Given this list of marker genes Grid2, Epha3, Kirrel1, Tbx18, Serpinb8, Il1rn, Nectin1, Cd40lg, Boc, Blm, Lypd11, Rap2b, Itga5 (NCBI Gene Id 16402), Sftpd, Cldn1, Erf, Pawr, Tjp3, Nckap1l, Cdh3, Adipoq, Itgb8, Celsr2, Ctnnd1, Alox12, Pik3cb, Cntn6, Il6st, Dcc, Robo1, Cldn15, S100a8, Cd80, Gpnmb, Igdcc3, Neo1, Zc3h12d, Egr3, Mypn, Itga2b, Rdx, Kirrel2, Cldn4, Rnase10, Epcam, Tsc2, Megf11, Emilin2, Smarce1, Il15, Mip, Traf6, Bloc1s4 (NCBI Gene Id 70328), Sh2b3, Dennd6a, Ccl21b, Cyld, Il23a, C1qtnf1, Scgb1a1, Pcdhb6, Fndc3a, Magi2 (NCBI Gene Id 50791), Foxo3, Srf, Nlgn3, Amigo3, Slc4a2, Cd4, Elane, Efnb2, Sox12, Gimap5, Pdia3, Il4i1, Ccl19, Bmp6, Bmp2, Cdhr2, Dsc2, Palld, Pard3, Peli1, Il6, Lrp5, Cdh12, Lgals1 (NCBI Gene Id 16852), Pcdh15, Cdh16, Irgm1, Mdga2, Csta2, Anxa9, Cd276, Ptafr, Ripk2, Epb41l5, Cd74, Cxadr, Spi1, Ccm2l, Prkcq, Pcdhga4, Kif26b, Pik3r6, Foxf1, Fga, Jup, Alox5, Madcam1, Cd24a, Tmx1, Zp3, Cd2, Tespa1, Capn1, Tnr, Cldn17, Ptk2, Pik3r1, Clstn3, Gm5849, Serpine2, Dusp22, Tcam1, Ets1, Ubash3b, Fcho1, Gpc4, Ndfip1, Btla, Lag3, Gstp1, Twsg1, Wnt10b, Egfr, Parva, Slc6a4, Kitl, Psen1 (presenilin 1), Slamf1, Crtam, Efr3a, Brd2, H2-Ob, Trpv4, Ap3b1, Pcdh12, Tln2, Nexn, Cd59b, Stk10, Il1rapl1, Msn, Fut9, Mink1, Hsp90aa1, Mad2l2, Cdh2, Pcdha10, Zdhhc2, Hmgb1, Runx1, Tnfsf11, Socs6, Ep300, Pkp1, Vegfa, Lrrc7, Cd34, Cxcl12, Cd160, Lamb1, Pcdhb18, Gata5, Lrrc4b, Cldn7 (NCBI Gene Id 53624), H2-Oa, Actl6b, Cd86, Zbtb7b, Plxnb2, Ptprm, Itga2, Cd2ap, Akna, Pcdh20, Ctsg, Pde5a, Comp (cartilage oligomeric matrix protein), Ywhag, Smarcc1, Adam19, Pdcd1lg2, Lrg1, Ctnna1, Apoa1, Cadm1, Negr1, Scarf1, Epo, Srpx2, Itgb2l, Dsg1c (desmoglein 1 gamma), Celsr3, Stfa2l1, Bmi1, Adgrl1, Shb, Nectin3, Pkhd1, H2-DMb2, Tmem47, Jak1, Chst4, Fstl3, Sell, Abca12, Btnl2, Selenok, Itga9, Cdh6, F2rl3, Fgl2, Ajuba, Aif1, Tnfaip3, Kifap3, Nlgn1, Tnfrsf13c, Wnt4, Dnaja3, Cd177, Rhoa, Il10, Ifng, Bad, Slc7a11, Tjp2, Rela, Pde4d, Dlg1, Map2k5, Abl1, Lrfn4, Vmp1, Vezt, Runx3, Cd46, Nrg1 (neuregulin 1), Prdx2, Pcdhb14, Cd93, Lrrc32, Pcdh10, Wnt5a, Efnb3, Bhlha15 (basic helix-loop-helix family, member a15), Igsf11, Socs1, Zfp608, Rac2, Adam9, Jag1, Igfbp2, Tarm1, Pkp2, H2-M3, Nptn, Ceacam1 (NCBI Gene Id 26365), Cd53, Cyp1b1, Ccl2, Htr2a, Nlgn2, Col13a1, Cldn14, Thbs1, Itgb2, Foxp3, Ccl21f, Cd44, Prkaa1, Fblim1, Bcl6, Bmp7, Dsg1b, Fat2, Smarcd2, Smarca2, Cblb, Cd28, Cd55b, Prkca, Celsr1, Mdk, Plpp3, Rapgef1, Cdh24, Slit2, Cd59a, Bsg (NCBI Gene Id 12215), Gm1123, Prkar1a, Prkcz, Adora2a, Pcdh19, Gp6, Lgals8, Lypd10, Cd5, Dnajb6, Ninj1, Elfn1, Vinac1 (vinculin/alpha-catenin family member 1), Mad1l1, Irf1, Chst2, Amigo2, Stxbp3, Cd1d1, Tenm3, Hmcn2, Il36b, Ceacam5, Cxcl13, Il21, Tnfsf18, Cd69, St3gal4, Cd200l2, Dtx1, Jak3, Ihh, Cdh7, Cd244a, Jam2, Mapk14, Olr1, Dscam, Ccr5, Cdh11, Cd81, Ada, Glmn, Mettl3, Ctla4, Cdh15, Rag2 (recombination activating gene 2), Opa1, Esam, Fadd (NCBI Gene Id 14082), Gnas, Il12b, Gp1ba, Slitrk2, Vsir, Adk, Ptpn22, Cdkn2a, Pla2g5, Clec4g, Icos, Pdcd1, Igf2, Adgrl3, Myot, Rasgrp1, Lpp, Tspan9, Ccn1, Nlrp3, Hspd1, Nck1, Igsf5, Efnb1, Golph3, Cplane2, Nck2, Gli3, Adamts18, Spta1, Ppia, Itgbl1, Pla2g2a, Ubash3a, Lax1, Coro1a, Zfp609, Selplg, Ccl25, Pcdha7, Sart1, Slc7a1, Rpsa, Itga6, Tnfrsf14, Tnfsf9, Rasal3, Lims2 (NCBI Gene Id 225341), Itga4, Ptprd, Plxnb3, Dsg3, Cntn5, Ppara, Tnfaip8l2, Dsg2, Cntn2, Thy1, Wnt1, H2-Eb1, Pcdhga12, Robo2, Il6ra, Itgb5, Mbp, Csta1, Fermt3, Cstdc3, Sfn, Itgb1, Itpkb, Kirrel3, Flot2, Pla2g2f, Tnfsf14, Dsg4, Irak1 (NCBI Gene Id 16179), Fgg, Marchf7, Syk, Arg2, Tgfb2, Lims1 (NCBI Gene Id 71899), Cd9, Cyfip2, Stfa3, Pkd1, Alcam, Tenm4, Btn2a2, Cdh9, Swap70, Vcam1, Colec10, Abl2, Ripor2, Robo4, Cyrib, Gldn, Cdh10, Taok2, Akt1, Anxa1, Cdh17, Il2, Mmrn1, Rag1, Clec7a, Mcam, Acvr1, Ptpru, Ctnnb1, Cdh13, Prickle1, Notch1, Cd1d2, Nfasc, Muc4, Carmil2, Lrrc4, Bmp5, Dsg1a, Jak2, Ezr, Card11, Itga1, Lef1, Ppp1ca, Il20rb, Stfa2, Fut7, Ctnna3, H2-Ab1, Cldn9, Gla, Rock1, Slfn1, Mapk7, Cdhr1, Il4ra, Pip5k1c, Stfa1, Dsc3, Cd300a, Fgb, P2ry12, Tnfrsf21, Dlg4, Cd274, Adtrp, Pvr, Cx3cr1, Cadm3, H2-Ea (NCBI Gene Id 14968), L1cam, Itga7, Havcr2, Cldn11, Cdon, Icam1, Nexmif, H2-T23, Nt5e, Nectin2, Il1a, Ildr2, Skint1, Ric8a, Il2ra, Pdpn, Itgb3, Pdia2, Cdh26, Brd4, Mag, Ptpn6, Apoa4, Ccdc88b, Cadm4, Kifc3, Gnrh1, Gcnt1, Vsig10l2, Vav1, Crb2, Cd83, Mia3, Fat1, Afdn, Clstn1, Dhps, Smarca4, Astn1, Skap1, Src, Emb, Has2, Smarcb1, Tnf, Shh, Igdcc4, Kat5, Lama3, Tek, Slitrk1, Megf10, Cldn22, Cdh4, Phf10, Lrp6, Itgam, Svep1, Atp2c1, H2-Eb2, H2-Aa, Sdc4, Tmem131l, Ascl2, Ccl21e, Arvcf, Cldn16, Stat5b, Tspan32, Adgrv1, Erbb2, Specc1l, Tnxb, Dsc1, Igsf9, Myh9, Stat5a, Tnip1, Rara, Pag1, Slitrk5 (SLIT and NTRK-like family, member 5), Il4, Wnt7b, Cdc42, Lep, Cdh1, Npnt, Ptprs, Klf4, Elfn2, Ifnb1, B4galnt2, Gata1, Cldn12, Hes1, Vtcn1, Pf4, Smarcd3, Cd3e, Rc3h2, Ret, Cd37, Rc3h1, Perp, Cx3cl1, Map2k1, Adam8, Smad7, Add2, Cited2, Crisp2, Notch4, Sele, Nfkbid, Cd200, Itga11, Jaml, Tjp1, Cldn10, Hfe, Cd47, Plekha7, Lrfn3, Gata3, Ephb4 (NCBI Gene Id 13846), Nf2, Ppp3ca, Arid2, Dsp, Lilrb4a, Arg1, Cntn1, Rhoh, Itgb7, Ptpn23, Tubb1, Gimap3, S100a9, Fgfrl1, Icam5, Pdgfra, Hmcn1, Dchs2, Ctnna2, Ccr2, Pcdh18, Scrib, Pck1, Dapl1, Jam3, Zdhhc21, Tgfbr2, Magi1, Itch, Itgav, Mpz, Icam2, Ccn3, Ptprc, Klhl25, Tgfb1, Nfat5, Cldn23, Pecam1, Bmp4, Shc1, Itgax (integrin alpha X), Prnp, Il18, Nodal, Pnp, Camsap3, Pnn, Hsph1, Nrarp, Cldn6, Unc5d, Gtpbp4, Cd209d (CD209d antigen), Lrfn5 (leucine rich repeat and fibronectin type III domain containing 5), Zc3h8, Fer (NCBI Gene Id 80679), Zmiz1, Cd6, Pkp3, Igsf9b, Entpd1, Pear1, Stxbp1, Mmp24, Fut4, Xbp1, Cdh22, Sox2, Piezo1, Sox4, Ccl28, Dlg3, Pcdhb8, F11r, Vcl, Rps3, Cav1, Spn, Lyn, Sema4d, Ido1, Cldn19, Lilrb4b, Xcl1, Sox9, Kit, Cdh20, Cstdc4, Il1rl2, Tln1, Lgals3, Nfkbiz, Cdh19, Cdsn, Ufl1, Nr5a2, Il2rg, Cd209c, Il1b, Aqp4, Cfh, Il1rap, Ext1, Laptm5, Amigo1, Ap3d1, Ctnnd2, Atp1b2, Il3, Actl6a, Bves, Prkg1, Podxl2 (NCBI Gene Id 319655), Cbll1, Socs5, Spint2, Crb1, Hlx (NCBI Gene Id 15284), Wnk1, Zap70, Slc39a8, Dchs1, Fat4, Mir326, Sox13, Ythdf2, Prtg, Itgae, Cd55, Igf1, Myo10, Pcdhgc3, Mex3b, Cstdc5, Thbs4, Fgl1, Gpam, Mdga1, Plek, Vnn1, Dock8, H2-DMb1, Tbx21, Ppm1f, Cd209e, Zbtb1, Loxl3, Tfrc, Nkap, Dlg5, Scarf2, Cdh18, Tmigd1, Pcdh1, Casp3, Klhl22, Ntng1 (netrin G1), Ptpn2, Lck, Smarcc2, Muc21, Nr4a3, Icam4, Chl1, Pcdha4, Mpzl2, Itga8, Epha7, Lgals9, Ceacam2, Flot1, Flrt3, Dusp3, Actb (NCBI Gene Id 11476), Itgal, Efna5 (NCBI Gene Id 13640), Tnfsf13b, Ephb6, Emcn, Cdh23, Csta3, Cldn8, Dab1, Dlg2, Cd27, Cstdc6, Pcdha9, Sparcl1 (SPARC-like 1), Itgad, Pdia6, Itga10, Itga3, Ccl5 (C-C motif chemokine ligand 5), Arid1a, Mfsd2b, Selp, Umod, Ass1, Sdk1, Cldn5, Il12a, Ccr7, Nrxn1, Vsig4, Pkp4, Zfp35, Gcnt2, Fat3, Myadm, Il7r (NCBI Gene Id 223338), Lrrc4c, Foxj1, Bcl2, Podxl, Ccl21d, Cdh8, Cd200l1, Tenm2, Bcl10, Fbxo38, Sirpa, Smarcd1, Crnn, Cbfb (core binding factor beta), Ptprt, Ntn1, Pcdh17, Cebpb, Ambra1, Cldn3, Nectin4, Hspb1, Clstn2, Il7, Vps33b, Rgcc, Itgb4, Brd7, Dscaml1, Icosl, Cadm2, Ank3, Slc4a1, Il12rb1, Tyk2, Zfp36l1 (zinc finger protein 36, C3H type-like 1), Wnt3a (wingless-type MMTV integration site family, member 3A), Ephb3, Nphs1, Cd200r1, Izumo1, Ntng2, Cdh5, Pcdh8, Astn2, Dpp4, Malt1, Pdia4, Sash3, Cdhr18, Tigit, H2-DMa, Tyro3, Pla2g2d, Ager, Pbrm1, Dusp10, Cd164 (CD164 antigen), Cbln1, Zfp703, Cela2a, Igsf21, Cldn18, B2m, Pycard, Ttyh1, Emilin1, Slitrk3, Lgals2, Ptprf, Rap1gap, Pten, Itgb6, Cdhr5, Nrcam, Plaur, Cldn2, Prkcd, Sdk2, Zc3h12a, Ncam1, Cdk5r1, Ccl21a, Tnfsf4, Alox15, Cdhr3, here is a description of the gene set: Mouse Gene Set: GOBP_CELL_CELL_ADHESION studied in species Mus musculus The attachment of one cell to another cell via adhesion molecules.